Given this list of marker genes Nt5c3, Nt5m, Dpys, Cda, Upb1, Dut, Dctpp1, Upp2, Dpyd, Nt5c, Upp1, Tymp, here is a description of the gene set: species: Mus musculus The chemical reactions and pathways resulting in the breakdown of a pyrimidine deoxyribonucleotide, a compound consisting of nucleoside (a pyrimidine base linked to a deoxyribose sugar) esterified with a phosphate group at either the 3' or 5'-hydroxyl group of the sugar. Mouse Gene Set: GOBP_PYRIMIDINE_DEOXYRIBONUCLEOTIDE_CATABOLIC_PROCESS